Given this list of marker genes Creb1, Rassf10, Phf19, Slco1b2, Rbm24 (RNA binding motif protein 24), Nat8l, Ppp1r3f, Tsc1, Cytl1, Akap13, Gga1, Sorcs1, Adam10, Cdc42ep4, Ctr9, Nexn, C9orf72, Anks1, Pfn2, Wasl, Prdm16, Ddah1, Galc, Fbxo11, Raph1, Dyrk1a, Fam53c, Caskin1, Gpbp1l1, Bicd2, Polm, Adcy1, Orm3, Mgat2, Plekhb2, Arhgef3, Sdk1, Dennd4b, Ppm1k, Plscr3, Cks2, Adamdec1, Stx5a, Smg1, Hivep3 (human immunodeficiency virus type I enhancer binding protein 3), Tbc1d24, Hnrnpul1, Gabrp, Traf3, Trhde, Ets1, Ccbe1, Phactr2, Obp1b, Thsd4, Lck, Mprip, Slc43a2, Kpna4, Pacs1, Ctdsp2, Ninj2, Prr13, Pecr, Adam19, Tnrc6b, Mtmr4, Chst4, Ntng1, H60b, Srsf7, Orm2, Ccn3, Poll, Cask, Tomm70a, Cnot6, Camsap2, Ror2, Cltc, Ankrd6, Tmem167b, Mrps27, Foxo1 (NCBI Gene Id 99758), Syne2, Hecw1, P3h3 (prolyl 3-hydroxylase 3), Orm1, Nr1d2, Bri3bp, Arih1, Slc5a12, Vdac2, Trim30d, Lamc1, Cadm3, Klrc1, Fhip2a, Dnm3, Ptger4, Epb41l5, Trim44, Tmprss2, Atf2, Bptf, Uba3, Tafa1, St3gal1, 5730507C01Rik, Il1r1, Tmem35a, Slc24a3, Shisal1, Anapc11, Orc4, Fam43a, Tent5a, Ahcyl2, Psme3ip1, Cdk6, Lelp1, Prrc2b, Vat1, Entrep3, Smim20, Csrnp3, Socs7 (NCBI Gene Id 97742), Actg1, Ryr1, Eif3b, Mtss1, Cd302, Gfpt2, Smad5, Picalm, Abraxas1, Akr1c20, Gdap1l1 (ganglioside-induced differentiation-associated protein 1-like 1), Esyt2, Susd6, Efna5, Jmjd4, Fbxl20, Map3k9, Arl8b, Ttyh2, Wipf2, Knstrn, Nub1, Polrmt, Anapc2, Fgf13, Llgl1, Kif14, Ccnl2, Rgs16, Crtac1, Tmem229b, Derl1, Rtl4, Grik2 (NCBI Gene Id 320644), Ercc6, Nova1, Ngly1, Sprr2e, Nr2c2 (nuclear receptor subfamily 2, group C, member 2), Epb41l4a, Cracdl, Ankrd33b, Senp2, Tmem231, here is a description of the gene set: from publication Chen Y, Wang X (PMID 31504780) Genes predicted to be targets of miRBase v22 microRNA mmu_miR_6996_5p in miRDB v6.0 with MirTarget v4 prediction scores > 80 (high confidence targets). Mouse Gene Set: MIR_6996_5P species: Mus musculus